The following is a description of a gene set: species: Mus musculus Mouse Gene Set: GOCC_OUTER_DENSE_FIBER A supramolecular fiber found in the flagella of mammalian sperm that surrounds the nine microtubule doublets. These dense fibers are stiff and noncontractile. In human, they consist of about 10 major and at least 15 minor proteins, where all major proteins are ODF1, ODF2 or ODF2-related proteins., and this is the list of marker genes: Ak1, Marcks, Ddx6, Flacc1, Odf4, Odf2, Tmem232, Ctsh, Cimap1a, Rsph1, Odf1, Txndc2